Given this list of marker genes ZNF362 (NCBI Gene Id 170467), ANAPC15, RPS4XP3, GAS2, CEP57, ACOT11, COL2A1, GABRQ, PARP4, ZSWIM8, FUT3, TNFSF10, RFX7, BCL2L14, MYH2, here is a description of the gene set: studied in species Homo sapiens Genes whose expression in primary ER(-) breast cancer tumors negatively correlates with developing distant metastases. Human Gene Set: WANG_METASTASIS_OF_BREAST_CANCER BACKGROUND: Genome-wide measures of gene expression can identify patterns of gene activity that subclassify tumours and might provide a better means than is currently available for individual risk assessment in patients with lymph-node-negative breast cancer. METHODS: We analysed, with Affymetrix Human U133a GeneChips, the expression of 22000 transcripts from total RNA of frozen tumour samples from 286 lymph-node-negative patients who had not received adjuvant systemic treatment. FINDINGS: In a training set of 115 tumours, we identified a 76-gene signature consisting of genes for patients positive for oestrogen receptors (ER) and genes for ER-negative patients. This signature showed 93% sensitivity and 48% specificity in a subsequent independent testing set of 171 lymph-node-negative patients. The gene profile was highly informative in identifying patients who developed distant metastases within 5 years (hazard ratio 5.67), even when corrected for traditional prognostic factors in multivariate analysis (5.55). The 76-gene profile also represented a strong prognostic factor for the development of metastasis in the subgroups of 84 premenopausal patients (9.60), 87 postmenopausal patients (4.04), and 79 patients with tumours of 10-20 mm (14.1), a group of patients for whom prediction of prognosis is especially difficult. INTERPRETATION: The identified signature provides a powerful tool for identification of patients at high risk of distant recurrence. The ability to identify patients who have a favourable prognosis could, after independent confirmation, allow clinicians to avoid adjuvant systemic therapy or to choose less aggressive therapeutic options. from publication Wang Y, Klijn JG, Zhang Y, Sieuwerts AM, Look MP, Yang F, Talantov D, Timmermans M, Meijer-van Gelder ME, Yu J, Jatkoe T, Berns EM, Atkins D, Foekens JA (PMID 15721472)